The following is a description of a gene set: studied in species Homo sapiens Human Gene Set: GOBP_REGULATION_OF_B_CELL_ACTIVATION Any process that modulates the frequency, rate or extent of B cell activation., and this is the list of marker genes: CD320, PTPN6, CHRNB2, CD22 (CD22 molecule), NOD2, MIR185, GPR183, INHBA, MIR17HG, SHLD3, PTPRC, PAXIP1, WNT3A, IL7, TNFSF13 (TNF superfamily member 13), PELI1, MZB1, RIF1, ATAD5, MLH1 (NCBI Gene Id 4292), TNFSF4, NSD2, SH3KBP1, LAPTM5, TNIP2, CD38, PCID2, SFRP1, SPI1, BTK, CD27, SASH3, AHR, BAD, TBC1D10C, IL13, HMGB3, SHLD2, IL2, CTLA4, TNFRSF13B, FCRL3, FCGR2B, PAWR, BST1, FOXJ1, CLCF1, KMT5C, MSH2, PPP2R3C, STAT6, CARD11, BCL6, MAD2L2, ZFP36L2, ID2, SLAMF8, EXOSC6, SLC39A10, EXOSC3, CR1, TICAM1, CYLD, IRS2, TNFAIP3, IL10, PMS2, IL6, STAT5B, TNFSF13B, SLC15A4, CD19, PKN1, IKZF3, THEMIS2, FOXP3, PRLR, STAT5A (NCBI Gene Id 6776), NCKAP1L (NCBI Gene Id 3071), XBP1, CD28, SUPT6H, MNDA, INPP5D, IL27RA, ATM, RC3H1, TCF3, TGFB1, CD40, MIF, CDKN1A, MEF2C, TNFRSF4, INHA, CASP3, ADA, TBX21, SAMSN1, TP53BP1, PARP3, TFRC, VAV3, CD81, NDFIP1, DDRGK1, IL4I1, BMI1, TLR9, BANK1 (NCBI Gene Id 55024), APLF, IL4, CD300A, KMT5B, TNFRSF13C, MMP14, IL5, IL2RG, ZFP36L1, TNFRSF21 (NCBI Gene Id 51323), LYN, HMCES, EPHB2, SHLD1, IL21, TIRAP, NFATC2, TYROBP, TLR4, AKIRIN2, BCL2, CDKN2A, SYK, CD74, NFAM1